Given this list of marker genes Slc28a2, Slc35b3, Slc29a1, Slc28a3, Atp2a1, Slc25a24, Slc28a2b, Slc37a2, Slc35d3, Slc25a5, Slc46a2, Slc25a54, Mfsd2a, Slc5a2, Ank, Slc35a1, Slc25a31, Slc25a4, Slc35b4, Slc35b2, Slc25a17, Slc15a3, Slc35d1, Slc35a5, Slc35d2, Lrrc8a, Slc22a2, Slc15a4, Slc29a3, Slc35e3 (NCBI Gene Id 77205), Slc25a41, Slc19a1, Slc50a1, Slc35b1, Slc22a1, Slc35c1, Slc29a4, Panx1, Slc25a25, Slc35a2, Slc17a9, Slc28a1, Abcc5 (ATP-binding cassette, sub-family C member 5), Slc25a23, Tmem241, Slc37a4, Slc5a1, Slc25a42, Slc35a3 (NCBI Gene Id 70398), Slc37a1, Slc25a26, Slc29a2, Abcc3, Slc17a5, here is a description of the gene set: species: Mus musculus Mouse Gene Set: GOMF_CARBOHYDRATE_DERIVATIVE_TRANSMEMBRANE_TRANSPORTER_ACTIVITY Enables the transfer of carbohydrate derivative from one side of a membrane to the other.